Given this list of marker genes Pex7, Pla2g4c, Far1, Agps, Alox5, Fasn, Selenoi, Gnpat, Peds1 (plasmanylethanolamine desaturase 1), Pla2g4a, Lpcat2, Chpt1, Pla2g5, Dhrs7b, here is a description of the gene set: The chemical reactions and pathways resulting in the formation of ether. species: Mus musculus Mouse Gene Set: GOBP_ETHER_BIOSYNTHETIC_PROCESS